The following is a description of a gene set: Human Gene Set: HP_INCREASED_INTRACRANIAL_PRESSURE An increase of the pressure inside the cranium (skull) and thereby in the brain tissue and cerebrospinal fluid. species: Homo sapiens Increased intracranial pressure, and this is the list of marker genes: C4A, PRF1, SNORD118 (NCBI Gene Id 727676), ELMO2, IRF4, ATM, CSPP1, KRAS, SDHD, FGFR3, PMS1, CHEK2, GALC, RAF1, HLA-B, MSH6, IFNGR1, APC, TGFBR2, UBAC2, TWIST1, CTSK (cathepsin K), ERF (ETS2 repressor factor), PDE4D, SEC23B, VHL, BAP1, BMPR1A, TLR4, SUFU (SUFU negative regulator of hedgehog signaling), RPS20, USF3 (NCBI Gene Id 205717), GALK1, GNA11, KIAA0586, NLRP3, FAS, CTNNB1, NRAS, POLE, BRCA2, STAT4, POLD1, PTEN, AKT1, TRAF7, IL10, ERAP1, TCF12, SMARCB1 (SWI/SNF related, matrix associated, actin dependent regulator of chromatin, subfamily b, member 1), DKK1, BRAF, ALX4, KLLN, PSAP, LRP5, SMO, L1CAM, FGFR1, NF2, EPCAM, CCND1, TERT, MSH2, IL23R, SOX5, IFT172, MLH1, ANTXR1, MEFV, SEMA4A, ZEB2, CASR, IL12A, CCR1, MUTYH, KLRC4, IL12A-AS1 (NCBI Gene Id 101928376), CCM2, PDCD10, FGFR2, SDHC, PIK3CA, PMS2, FREM1, SDHB, ALK, ZIC1, PDGFB, SMARCE1, KRIT1, SOST